Given this list of marker genes Psmb9, Isg15, Ly6e, Ms4a4b, Ifi47, Zbp1, Psme2, Ifit3, Ms4a4c, Tapbp, Stat1, Gbp4, Psmb10, H2-T23, Irgm1, Rtp4, Parp14, Psmb8, Samhd1, Tap1, Bst2, Gimap4, Igtp, Ifi27l2a, Gbp2, Ly6a, Iigp1, Psme1, Rnf213, Ifit1, here is a description of the gene set: Genes positively differentially expressed in cell type: CD4+ T cell upon treatment with cytokine: IL-27 in mouse lymph nodes in vivo. from publication Cui A, Huang T, Li S, Ma A, Pérez JL, Sander C, Keskin DB, Wu CJ, Fraenkel E, Hacohen N (PMID 38057668) Mouse Gene Set: CUI_T_CELL_CD4_IL27_RESPONSE_UP species: Mus musculus Cytokines mediate cell-cell communication in the immune system and represent important therapeutic targets. A myriad of studies have highlighted their central role in immune function, yet we lack a global view of the cellular responses of each immune cell type to each cytokine. To address this gap, the authors created the Immune Dictionary, a compendium of single-cell transcriptomic profiles of more than 17 immune cell types in response to each of 86 cytokines (>1,400 cytokine-cell type combinations) in mouse lymph nodes in vivo. A cytokine-centric view of the dictionary revealed that most cytokines induce highly cell-type-specific responses. For example, the inflammatory cytokine interleukin-1β induces distinct gene programmes in almost every cell type. A cell-type-centric view of the dictionary identified more than 66 cytokine-driven cellular polarization states across immune cell types, including previously uncharacterized states such as an interleukin-18-induced polyfunctional natural killer cell state.